The following is a description of a gene set: Human Gene Set: HP_INCREASED_URINARY_CORTISOL_LEVEL Abnormally increased concentration of cortisol in the urine. Increased urinary cortisol level species: Homo sapiens, and this is the list of marker genes: ARMC5, KDM1A (NCBI Gene Id 23028), CDKN2A, CTNNB1 (catenin beta 1), USP8, GNAS, USP48, NR3C1, BRAF, TP53, TERT, ZNRF3, PRKAR1A, ATRX, CDH23, CDKN1B